Given this list of marker genes Actr2, Fbxo31, Tnik, Fzd4, Cdkl5, Marcks, Pafah1b1, Fbxw8, Ephb2, Sh3glb1, Akap5, Wls, Cul7, Mfn2, Mfn1, Xlr3b, Kalrn, Slc30a1, Opa1, Pak3, Tiam1, Ss18l1, Cux2, Anapc2, Itpka, Grip1, Sgk1, Ache, Epha4, Caprin2, Caprin1, Dnm1l, Wnt5a, Dbnl, Cux1, Il1rapl1 (interleukin 1 receptor accessory protein-like 1), Myo5b, Numb (NUMB endocytic adaptor protein), Ptprf, Rab21, Cdkl3, Ilk, Met, Actr3, Bhlhb9, Eef2k, Afdn, Baiap2, Dlg4, Prkdc, Pias2, Stau2, Parp6, Hdac6 (histone deacetylase 6), Dhx36, Numbl, Mpl, Dbn1, Obsl1, Lrp8, Tbc1d24, Cask, Camk2b, Ptprd, Ankrd27, Reln, here is a description of the gene set: Mouse Gene Set: GOBP_POSITIVE_REGULATION_OF_CELL_MORPHOGENESIS studied in species Mus musculus Any process that increases the frequency, rate or extent of cell morphogenesis contributing to cell differentiation. Cell morphogenesis involved in differentiation is the change in form (cell shape and size) that occurs when relatively unspecialized cells acquire specialized structural and/or functional features that characterize the cells, tissues, or organs of the mature organism or some other relatively stable phase of the organism's life history.